Given this list of marker genes PPP2CB, CDC20, NSL1, PSMA1, UBB, HDAC8, CENPA, CENPT, NUP155, ANAPC7, TUBB8B, NUP160, CDCA8, PSMB4, POM121, PSMD6, PSMA3, PMF1, CC2D1B, SKA2, PSMC6, DYNC1LI2, PSMA7, TUBA4B, PPP2R1B, PSMB7, UBE2E1, NUP188, PLK1, CENPQ, DYNC1I1, CENPS, KNTC1, NUP43, KIF2C, SGO1, PSMD7, PSMB6 (NCBI Gene Id 95505), NDC80, PSMD2, CENPP, CENPM, PPP2R2A, TUBA4A, ZWINT, CENPH, CDC27, CCNB1, KPNB1, STAG2, NUF2, RPS27, IST1, CHMP4A, LEMD3, TUBA3C, BIRC5, CENPO, SEC13, XPO1, SPAST, SGO2, PPP2R5C (NCBI Gene Id 63377), PSMA5, BUB1, MAD1L1, SEH1L, DSN1, ANAPC11, UBE2I, KIF2B, NUP62, ANKLE2, LMNB1, STAG1, BANF1, PSMB3, NUP98, PSMA4, DYNC1H1, PPP1CC, TUBB2B, TNPO1, PPP2R5E, PPP2R5B, ANAPC5, TUBA3E, TUBA8, ZWILCH, NDEL1, TUBB3, VRK1, RCC2, INCENP, CDC23, UBE2D1, TUBB4B, PAFAH1B1, CENPE, SPDL1, KIF2A (NCBI Gene Id 3796), TUBA1B, UBC, SKA1 (NCBI Gene Id 220134), PPP2R1A, SPC25, RANGAP1, NUP37 (nucleoporin 37), CHMP6, BUB1B, LMNA (lamin A/C), CLIP1, PSMC2, SMC1A, PSMA2 (NCBI Gene Id 5683), NDC1, ANAPC10, SEM1, PPP2R5D, MIS12, TUBB1, SPC24, ANAPC15, PSMD1, WAPL, RAD21, CCNB2, NUP93, UBE2C, NUP133 (nucleoporin 133), ANAPC2, EMD, RAN, TUBB2A, NUP205, CLASP1, UBA52 (ubiquitin A-52 residue ribosomal protein fusion product 1), LBR, PPP2R5A, ADRM1, NDE1, RPS27A, ERCC6L, PSMC3, CDC16, PSMA6, CLASP2, CHMP7, CENPC (centromere protein C), PSMD14, AURKB, CDCA5, PSMD13, NUP58, B9D2, SUMO1, TUBA1A, PPP2CA, CKAP5, CHMP4B, CHMP2A (NCBI Gene Id 27243), CENPF (centromere protein F), NUDC, PSMD8, MAPRE1, NUP35, PSMB5, CDC26, KNL1, ANAPC4, DYNLL1, PSMD12, ANAPC1, DYNC1LI1, PDS5A (NCBI Gene Id 23244), PSMB2, UBE2S (NCBI Gene Id 27338), CDK1, CHMP4C, PSMC1, TUBA3D, CENPN, RANBP2, ANAPC16, CENPU, PSMC4, TMPO, CHMP2B, TAOK1, RCC1, MAD2L1, TUBB8, VPS4A, CENPL, NUP107, VRK2 (NCBI Gene Id 7444), SMC3, PTTG1, PSMD3, DYNC1I2, ESPL1, TUBB6, NUP54, AHCTF1, PSMD11, NUP85, PSMC5, CENPK, CHMP3, PSMB1, ZW10, DYNLL2, SIRT2, CENPI, KIF18A (kinesin family member 18A), TUBA1C, ITGB3BP, TUBAL3, LEMD2, BUB3, PDS5B, TUBB4A, here is a description of the gene set: Reactome Pathway: Mitotic Anaphase species: Homo sapiens part of: Mitotic Metaphase and Anaphase In anaphase, the paired chromosomes separate at the centromeres, and move to the opposite sides of the cell. The movement of the chromosomes is facilitated by a combination of kinetochore movement along the spindle microtubules and through the physical interaction of polar microtubules.